The following is a description of a gene set: species: Mus musculus Mouse Gene Set: GOMF_MONOATOMIC_CATION_TRANSMEMBRANE_TRANSPORTER_ACTIVITY Enables the transfer of cation from one side of a membrane to the other., and this is the list of marker genes: Cacna1s, mt-Atp8, Kcna7, Kcnmb1, Kcnb1, Fxyd1, Zdhhc13, Slc36a1, Ndufv2, Gria2, Cacna2d1, mt-Nd6, Fxyd4 (FXYD domain-containing ion transport regulator 4), Slc4a4, Kcnt2, Slc28a1, Atp13a5, Grin2a, Slc4a5, Atp2c1, Slc9b2, Trpc6, Snta1, P2rx3, Atp2a1, Ndufs8, Kcns1, Slc39a7, Atp6v1b2, Nipal4, Atp6v0d2, Ano10, Atp1a1, Kcnk1, Atp6v1d, Slc24a1, Sec61a1, Slc38a5, Mcub, Fgf12, Calhm2, Atp6v1h, Kcnk2, Slc9a2, Ndufs3, Slc39a12, Pkd1l3, Slc10a4-ps, Slc5a9 (solute carrier family 5 (sodium/glucose cotransporter), member 9), Akt1, Cav3, Tfrc, Ndufb7 (NADH:ubiquinone oxidoreductase subunit B7), Rem1, Slc17a8, Bnip1, Trpv4, Abcc9, Slc9c1, Slc38a7, Flna, Mcoln2, Scnn1b, Slc16a1, Nalcn, Kcnf1, Ctns, Prss8, Slc1a6, Atp6v1c2, Cnga4, Nedd4l (neural precursor cell expressed, developmentally down-regulated gene 4-like), Slc18a3, Chrna6, Anxa5, Kcnj6, Kcne4, Slc12a3, Kcnc4 (potassium voltage gated channel, Shaw-related subfamily, member 4), Atp2c2, Wnk4 (NCBI Gene Id 69847), mt-Nd4, Kcnh4, Best2, Ndufs7, Cabp4, Mmgt2, Slc16a3, P2rx5, Slc1a2, Gria1, Kcna3, Asic4, Slc39a10, Kcnk13, Slc5a12, Slc6a7, Itpr1, Slc22a5, Slc10a3, Scn10a, mt-Nd4l, Snap25, P2rx6, Nipal2, Slc5a2, Kcna4, Kcnj3, Slc9a6, Kcnn4, Kcnj11 (potassium inwardly rectifying channel, subfamily J, member 11), Orai2, Tmc2, Lrrc38, Slc38a3, Ccdc51, Commd1, Fxyd5, Wnk3, Scn7a, Panx3, Pkd2l1, Kcne2, Otop3, Kcng2, Atp6v1e1, Slc6a14, Slc32a1, mt-Nd5, Kcnd3, Slc6a13, Slc24a2, Slc6a1, Tmbim6, Hamp, Calhm5, Kcnmb3, Kcnb2, Slc41a3, Pias3, Nipa2, Agt, Kcne1, mt-Cytb, Ywhah, Kcnk18, Kcnip4, Grik3, Kcnk5, Ryr2, Atp6v0e, Grm3, Slc5a10, Cachd1, Tmem94, Slc5a6, Lrrc52, Slc6a15, Asic1, Slc12a2, Ptpn3 (protein tyrosine phosphatase, non-receptor type 3), Cabp2, mt-Co2, Slc9a7, Atp13a2, Slc45a3, Calhm3, Fxyd7, Kcnma1, Trpm3, Atp5pd, Slc4a9, Kcne3, Gpd1l, Kcnk16, Grin2d, Atp5mc2, Slc1a1, Kcnq1, Pkdrej, Cacng1, Slc34a3, Trpm8, Ryr1, Cacnb1, Trpm6, Rem2, Slc29a1, Atp5po, Atp7a, Trpa1, Scn2a, Slc10a1, Tmem175, Catsper3, Chrnb2, Atp5f1d, Scn11a (sodium channel, voltage-gated, type XI, alpha), Kcnt1, Atp2a3, Slc28a2, Slc25a4, Slc24a5, Atp7b, Gpm6a, Cacna1e, Ano1, Slc30a6, Cpox, Asic5, Slc28a2b, Slc15a1, Kcna2, Kcnj13, Chrng, Slc5a11, Calm1, Slc39a5, Nos1, Slc30a8, Stim1 (stromal interaction molecule 1), Cacng7, Letm1, Slc10a5, Kcnk3, Grin1, Romo1, Grm2, Chrne, Itpr3, Sclt1, Cabp1, Chrnb4, Psen1 (presenilin 1), Atp5f1a, Hvcn1, Kcnv2, Chrna10, Kcnj12, Scnn1a, Kcnj14, Slc13a4, Slc5a5, Slc5a4a, Atp1b3, Abcc8, Otop1, Nipa1, Prkcz, Htr1b, Grin3b, Cngb1, Kcnj16, Slc36a3, Atp1b1, Clcn7, Atp5mg, Chrnd, Cacng3, Arpp19, Sgk1, Ucp1, Cacng8, Slc40a1, P2rx7, Kcnu1, Slc5a3, Calm3, Slc20a2, Prkg1, Kcnmb2, Scn3a, Trpm2, Crisp4, Slc6a12, Calhm6, Cacng6, Trpv1, Mcoln3, Catsper4, Atp4b, Atp1b2, Ank2, Slc1a3, Camk2d, Slc39a2, Tmbim4, Kcnd2, Chrna5, Piezo1, Atp1a3, Mcoln1, Trpv2, Fgf13, Catsper2, Scn2b, Kcnc1 (potassium voltage gated channel, Shaw-related subfamily, member 1), Trpm4, Chp1, Slc34a1, Pde4d, Fgf14, Atp6v0c, Kcnn3, Hpcal4, Pex5l, Chrna4, Gria3, Tmem63c, Slc18a1, Pkd2l2, Slc39a6, Scn3b, Ndufs2, Slc11a1 (NCBI Gene Id 18173), Kcne5, Cox7a1, Rangrf, Cacna1g (NCBI Gene Id 12291), Slc8a2, Otop2, Slc46a1, Ndufa2, Atp12a, Atp6v0a1, Slc9a8, Trpc7, Trpv5, Slc36a2, Atp6v0a4, Slc8a3, Ndufa10, Nnt, Grik4, Stx1a, Atp5mf, Kcnk7, Slc39a14, Ndufv1 (NADH:ubiquinone oxidoreductase core subunit V1), Cyc1, Tusc3, Slc1a7, Atp5f1b, Slc2a4, Ryr3, Faim2, Kcnj10, Phpt1, Slc6a11, Tmem109, Piezo2, Kcnj5, Cacng2, Kcnq3, Slc41a2, Kcnk12, Pkd2, Cacna2d2, Stimate, Cnnm2, Mfsd2a, Cav1, Atp2b3, Slc2a13, Ano9 (anoctamin 9), Slc30a1, Itpr2, Slc13a1, Chrna1, Pcsk9, Slc10a4, Atp5mc1, Slc15a4, Tmc1, Slc30a9, Grik5, Aqp1, Amigo1, Cnga2, Panx1, Cox5a (NCBI Gene Id 12858), Slc47a1, Cacna1f, Cacna1d, Slc25a3, Tpcn2, Lrrc26, Tmem150c, Chrna7, Slc4a10, Nrxn2, Slc9a5, Slc25a14, Cacnb3, Atp6v1a, Glrx, Slc12a7, Slc5a4b, Slc18b1, Slc9a4, Nrxn3, Slc20a1, Nipal1, Trpm1, Hcn3, Cnnm4, Pacsin3, Slc6a20b, Kcnn1, Slc38a1, Rimbp2 (NCBI Gene Id 231760), Rrad, Tomm40, Kcnip2, Nipal3, Kcnip3, Slc18a2, Kcnip1, Kcng3, Atp6v1e2, Kcnh6, Atp1a2, Fxyd2, Kcna10, Kcnk6, Tmbim1, Uqcrh, Cnga1, Slc28a3, Atp5f1e, Sting1, Tmco1, Slc25a22, Slc4a11, Uqcrfs1, Scn8a, Slc6a9, Grik1, Trpv3, Tmem38b, Tmem63b, Cacna1a, Cnga3, Slc5a8, Uqcrh-ps1, Slc25a12, Gpld1, Kcnq5, Grin2c, Cngb3, Ywhae, Atp2b2, Dpp6, Kcnc2, Chrna9, Grina, Slc17a7, Kcnj15, Atp5me, Slc13a3, Atp6v0b, Trpc1, Slc6a20a, Kcnmb4, Scn1b, Ensa, Slc23a2, mt-Co3, Slc30a5 (solute carrier family 30 (zinc transporter), member 5), Kcng4 (potassium voltage-gated channel, subfamily G, member 4), Dpp10, Hamp2, Atp2b4, mt-Nd2, Trpv6, Slc22a3, Slc11a2, Scn4b, Kcng1, Slc25a28, Slc5a1, Scn5a, Kcnab3, Slc39a3, Prss30, Itgav, Tmbim7, Lrg1, Tmem63a, Slc39a11, Kcnn2 (NCBI Gene Id 14301), Atp6v1g2, Slc6a5, Pkd1, Chrnb1, Atp4a, Scn1a (NCBI Gene Id 227987), Trpc3, Ucp2, Slc9a1, Chrna2, Surf1, Akap9, Hcn2, Atp13a3, Atp13a1, Kcnh3, Atp5f1c, Kcnq2, mt-Nd3, Cybb (NCBI Gene Id 97621), Clcn3, Adrb2, Slc39a13, Grik2, Slc25a5, Sgk3, Hcn4, Kcnq4, Slc45a4, Slc12a1, Htr3b, Cacna1b (NCBI Gene Id 99436), Ncs1, Slc24a3, Kcnj2, Mcu, mt-Atp6, Slc6a4, mt-Nd1, Mmgt1, P2rx2, Slc25a37, mt-Co1, Tmem38a, Slc12a9, Slc6a8, Slc8b1, Slc25a13, Kcnd1, Cox4i2, Dlg1, Fxyd3, Tmco3, Slc25a18, Oprm1, Slc41a1, Slc38a2, Slc8a1, Slc9a9, Atp5mc3, Atp6v1g1, Slc4a7, Slc30a4, Mrs2, Hrh1, Cacna1c, Kcna5, Slc30a3, Cacnb4, Atp2a2, Unc80, Fxyd6, Tspoap1 (TSPO associated protein 1), Tspan13, Rasa3, Slc31a2, Atp6v0d1, Kcnj1, Lrrc55, Slc12a6, Kcnh2, Slc39a9, Wnk1, Kcnj8 (potassium inwardly-rectifying channel, subfamily J, member 8), Atp6v1b1, Slc10a6, Htr3a, Slc30a2, Atp13a4, Slc12a4, Cacna2d4, Nalf1, Nrxn1, Tpcn1, Trpc2, Pkd1l1, Ndufs4, Magt1, Atp5pb, Kcnab1, Tmem168, Kcnh1, Slc6a6 (NCBI Gene Id 97306), P2rx1 (purinergic receptor P2X, ligand-gated ion channel, 1), Kcnh8, Kcnk15, Slc30a7, Micu3, Scnn1g, Atp6v1g3, Slc25a27, Slc45a1, Cacna2d3, Kcnc3, Cacnb2, Slc23a1, Slc39a8, Gm5134, Scn4a, Orai3, Tmem37, Slc24a4 (solute carrier family 24 (sodium/potassium/calcium exchanger), member 4), Slc39a4, Slc12a8, Cacng4 (NCBI Gene Id 54377), Ucp3, Slc46a3, Calhm1, Atg5lrt, Kcnk9, Slc15a2, Tnni3, Trpm5, Ano6, Atp2b1, Sgk2, Trpm7, Calm2, Cacng5, Kcnv1, Slc4a8, Slc9a3, Scn9a, Slc6a2, Orai1, Slc13a2, Gnb2, Atp6v0e2, Kcnh7 (potassium voltage-gated channel, subfamily H (eag-related), member 7), Slc29a4, Wnk2 (NCBI Gene Id 75607), Grm7, Tmprss3, Sumo1, Slc30a10, P2rx4, Slc13a5, Ghitm, Atp6v1c1, Slc47a2, Atp6-ps, Cacna1h, Slc34a2, Nalf2, Grin3a, Kcns2, Grin2b, Atp6v0a2, Tmem165, Micu2, Kcnab2 (potassium voltage-gated channel, shaker-related subfamily, beta member 2), Cabp5, Prkcb, Slc10a2, Kcna1, Atp1a4, Ndufs1, Slc22a1, Pkd1l2, Calhm4, Nedd4, Slc45a2, Micu1, Atp5pf, Slc12a5, Slc6a18, Asic3 (acid-sensing ion channel 3), Hcn1, Catsper1, Kcnj4, Chrnb3, Kcnk4, Fgf11, Slc6a3, Slc39a1, Slc17a6, Stim2, Gem, Asic2, Trpc5, Trpc4, Kcnh5, Kcns3, Kcnk10, Slc38a4, Atp6v1f, Chrna3, Kcnj9, Kcna6, Fkbp1b, Slc31a1, Cacna1i, Slc5a7